Given this list of marker genes Lrrtm3, Sema5a, Lin52, Usp44, Odr4, Arhgap12, Sftpa1, Psd3, Ptpn3, Asb5 (ankyrin repeat and SOCs box-containing 5), Alox15, Med1, Col5a2, Mkx, Mex3c, Cimip2b, Slc45a3, Stim1, Vcl, Bfar, Dcaf12, Ccp110, Sugct, Sema3a, Poln, Ly6i, Babam1, Dhrs7b, Bptf (bromodomain PHD finger transcription factor), Btaf1, Rsph4a, Elavl2, Brdt, S1pr2, Erap1, Cdh11, Armcx3, Mcidas, Stag1, Blcap, Pcnx1 (pecanex 1), Sec61a2, Serpinb6c, here is a description of the gene set: studied in species Mus musculus Mouse Gene Set: MIR_7093_5P from publication Chen Y, Wang X (PMID 31504780) Genes predicted to be targets of miRBase v22 microRNA mmu_miR_7093_5p in miRDB v6.0 with MirTarget v4 prediction scores > 80 (high confidence targets).